The following is a description of a gene set: Genes predicted to be targets of miRBase v22 microRNA hsa-miR-520f-5p in miRDB v6.0 with MirTarget v4 prediction scores > 80 (high confidence targets). Human Gene Set: MIR520F_5P studied in species Homo sapiens from publication Chen Y, Wang X (PMID 31504780), and this is the list of marker genes: RPAP3, SUPT3H, QKI, ING2, LYRM7, METTL6, E2F4, CR1, DTWD2, KCNC2, TMPRSS11E, CDIP1, ZEB2, FAXC, YAP1 (NCBI Gene Id 10413), HMBS, ANKRD13A, SAXO2, EPS8, ASB4, OSR2, CCDC186, PSMD12, SMAD1, ETFDH, TWIST1, MCTP1, CDC27, ZMYM2, C16orf54, NOVA1, ITGA4, FHL5, CXXC5, LYSMD4, CCDC6, PLPBP, SMARCE1, MPLKIP, GPNMB, SPIRE1, CASK, SLC4A8, C1orf52, NUDT11, ARHGAP39, GABRA4, AGO3, SEPTIN6, SLC25A24, CDC26, ZNF3, AKAP8, NPR3, JARID2, PPM1L, TAT, ING3, VWA5A, YPEL1, HABP2, PAPOLA, PRPSAP2, USP9X, LSAMP, PFKFB2, SCHIP1 (schwannomin interacting protein 1), SOAT1, EXOSC6, KIAA0232, CCDC8, DHX33, ZNF592, TBX2, GLT6D1, LTA4H, TSPAN12, PMP2, LGR5, GNAI2, GRIA4, CDH8, TSTD3, PTGDR, MRPL9 (NCBI Gene Id 65005), RAB8B, SLU7, DBT, CYLD, RB1, CACHD1, CTNND1, NUP214, CPEB2, MAP7, YTHDC2, ATL2, RTKN2, MAPK10, PLPPR4, UBE4A, FXR1, NHLH2, SIM1, PHLPP2, GAREM1, DNAJC22, PPIL1, ERCC6L2, DENND5A, ZBTB41, GPR132, SPNS2, CPOX, NABP1, SRP9 (NCBI Gene Id 6726), SLC50A1, RASAL2, MED21, SLC38A1, TMPO, SALL1, MSANTD2, EFHC1, IQCJ-SCHIP1, BCL2L11, KMO, KLF3, RELCH, MEGF10, NECAB1, DPH6, TMEM209, PLSCR5, DNAJC25-GNG10, GRIA3, RC3H1, LRP8, TMX4, CADM1, REST, PSME3IP1, PMM1, HAPSTR1, RAB27B, SPATS2L, C3orf38, GIPC2, PRP4K, FABP2, GCNT4, RDH12, PVR, TMX1, GNG10, SMAD5, SLTM, GDF2, ETFBKMT, LIMA1 (LIM domain and actin binding 1), LSM5, RNF175, TMEM241, FEM1C, ABCG1, CDC25A, BPGM, GAL3ST4, CAAP1, PCLO, MTFMT, ADAM10, UTY, CCDC71L, TRIM32, MEF2A, ZNF470, KCTD7, TECRL, INSC, HTR1F, ZBTB20, ATP10D, LBX2, GAD1, PSTPIP2, AIG1, ZKSCAN5, PPP1R3E, NDUFA4, MXD1, CALU, SHISA9, TRA2A, NCOA7, LRP2, ALCAM, ZBTB18